The following is a description of a gene set: Optic disc pallor studied in species Homo sapiens Human Gene Set: HP_OPTIC_DISC_PALLOR A pale yellow discoloration of the optic disc (the area of the optic nerve head in the retina). The optic disc normally has a pinkish hue with a central yellowish depression., and this is the list of marker genes: REEP6, PEX1, CC2D2A, SMG8, LYRM7, TMEM126A (transmembrane protein 126A), TRNT1, ATF6, AP4M1, MKS1, OPA1, KCNC3, RPGRIP1 (RPGR interacting protein 1), FANCI, PCARE, CACNA1F, IDH3B, BBS5, PCYT1A, CERKL, NDUFAF4, IFT140, NR2F1 (nuclear receptor subfamily 2 group F member 1), OPN1MW, SLC7A14, VPS41, RBP3, ARL2BP, PDXK, NDUFS2, ABCA4, NDUFA11, MVK, NDUFA1, RIMS1, TIMMDC1, MT-ND3, ATXN1 (NCBI Gene Id 7912), TUBB4B, NGLY1, GRID2, TOPORS, CFAP418, BEST1, CNNM4, CDHR1, ELOVL1, NUBPL, ARL3, FLRT1, RLBP1, SCAPER, TULP1, AFG3L2, MAK, TTC8 (tetratricopeptide repeat domain 8), KCNJ13, LCA5, C1QTNF5, ZNF513, SAG, NDUFS6 (NADH:ubiquinone oxidoreductase subunit S6), AP3B2, NDUFB3, DPAGT1, RTN4IP1, PDE6B, NDUFV1, KIF5A, PRPF6, OFD1, TTLL5, RP2, MFRP, MCAT, AIPL1, RDH12, MAPKAPK5, HNRNPH1, TUBGCP6, ERCC6 (ERCC excision repair 6, chromatin remodeling factor), PCLO, MYOC, PRCD, RGR, EFEMP1, IFT88, RIMS2, IFT43, TMEM67, PLK4, MERTK, GUCY2D, MAN2B1 (mannosidase alpha class 2B member 1), POC1B, KLHL7, PRPH2, RAX2, JAM3, FAM161A, EYS, GNAT1, NDUFV2, ZNF408 (zinc finger protein 408), PRPS1 (phosphoribosyl pyrophosphate synthetase 1), MT-ATP6, COL4A1, AHR (NCBI Gene Id 196), RAB28, GDF6, BBS1, MMP19, CLDN11, AGBL5, UBE3B, SEMA4A, NUS1, COL18A1, PARS2, RP9, ROM1, MSTO1, NDUFAF1, SPATA7, MFSD8, GUCA1A, HGSNAT, STX3, MT-ND2, IFT172, PITPNM3, CACNA2D4, RD3, ADAM9, NDUFAF5, OPN1LW, CRB1, CNGA1, TASP1, COX7B, CYP27A1, NDUFB9, MTFMT, HLA-A, RP1L1, ERCC8, IMPG2, NRL, PDE6G, INPP5E, RTTN, CLRN1, ARL6, CLCN7, TOR1A, PISD, NDUFS8, FSCN2, PANK2, OSTM1, POMGNT1, ACO2, NDUFS7, FGF12, ITM2B, SNRNP200, NDUFS3, PIGB, NDUFAF2, KIZ, ALMS1, DHDDS, CNGA3, CYP1B1, HK1, BBS2, NDUFC2, DNM1L, SAMD7, DARS1 (aspartyl-tRNA synthetase 1), LRAT, NDUFA13, ARHGEF2, CRX, PIGA, DRAM2, IMPDH1, TMEM126B, ARHGEF18, NDUFS1, NEDD4L, MFF, TUB, MFN2, PDE6A, TPI1, WFS1, HARS1, RPGR, PRPF3, RRM2B (ribonucleotide reductase regulatory TP53 inducible subunit M2B), PRPF4, ACER3, CNGB1, CFAP410 (NCBI Gene Id 755), AHI1, KLC2, BLOC1S3 (biogenesis of lysosomal organelles complex 1 subunit 3), IQCB1, TMEM106B, NDUFAF3, NDUFS4, GFM2, ARL13B, TLCD3B, NR2E3, CA4, NMNAT1, NDUFAF8, PRPF8, RP1, KIAA1549, USP45, NDUFB11, EXOC8 (NCBI Gene Id 149371), NDUFB10, IDH3A, VSX1, NEK2, RHO, MIEF1, IMPG1, UNC119, PRPF31, SPG7, NDUFA6, SDHD (NCBI Gene Id 91899), CLCC1, CEP290, CLN8, AIFM1, RPE65, MT-ND1, PROM1 (NCBI Gene Id 9634), PRORP, MECR, CASK, MAG, ESPN, DYRK1A, USH2A, OPA3, NFIX, GUCA1B, FOXRED1, B3GALT6, DHX38